Given this list of marker genes PSAT1, SCN9A, SCN1A, SCN2A, GABRA1, PCDH19, GABRG2, SCN1B, here is a description of the gene set: Cyanotic episode Human Gene Set: HP_CYANOTIC_EPISODE studied in species Homo sapiens